Given this list of marker genes Fkbp4, Fkbp8, Ppm1k, Dusp29, Ppef2, Ppm1n, Pin1, Dusp4, Cdk13, Ppm1m, Dusp15, Ppia, Ssh1, Epm2a, Fkbp2, Ppm1g, Dusp2, Ppp2cb, Ppm1d, Ppid, Fkbp9, Cpped1, Fkbp10, Ppic, Ppil4 (NCBI Gene Id 76735), Ppm1h (protein phosphatase 1H (PP2C domain containing)), Dusp19, Ppif, Ppp3ca (protein phosphatase 3, catalytic subunit, alpha isoform), Ptpmt1, Ppef1, Dusp10, Ppp3cc, Rpap2, Dusp23, Nktr, Ppwd1, Dusp21, Ppm1b, Cdc14b, Ppm1l, Dusp13a, Phlpp1, Ppm1a (NCBI Gene Id 72917), Ptpa, Ctdsp2, Ssh2, Dusp3, Ppih, Pin4, Pptc7, Eya1, Ppm1f, Ppp2ca, Ctdsp1, Ssu72, Phlpp2, Fkbp1a, Dusp14, Ublcp1, Dusp7, Cdk12, Cdk7, Brd4, Cdk8, Pgam5, Ppp6c, Ppil1, Ppp1ca, Ctdnep1, Dyrk1a, Cdk9, Dusp26, Ppil3, Ppp3cb, Dusp13b, Dusp28, Dusp1, Ctdspl2, Ssh3, Fkbp5, Ctdp1, Fkbp3, Ilkap, Fkbp7, Ppig (peptidyl-prolyl isomerase G (cyclophilin G)), Dusp8, Pten, Ppie, Mapk1, Cdk1, Ctdspl, Dusp18, Dusp12, Ppm1e, Dusp22, Ppp1cc, Cdc14a, Fkbp11, Dusp6 (NCBI Gene Id 67603), Pdxp, Ppm1j, Cdkn3, Ppp4c, Ppp5c (protein phosphatase 5, catalytic subunit), Fkbp1b, Ppp1cb, Ccnk, Ppib, Fkbp14, here is a description of the gene set: species: Mus musculus A catalytic activity that acts on the RNA polymerase II large subunit CTD heptapeptide repeat (consensus YSPTSPS). Reversible modifications cof the RNA polymerase II CTD repeats contribute to regulation of RNA polymerase activity. Mouse Gene Set: GOMF_RNA_POLYMERASE_II_CTD_HEPTAPEPTIDE_REPEAT_MODIFYING_ACTIVITY